The following is a description of a gene set: Genes predicted to be targets of miRBase v22 microRNA mmu_miR_6358, mmu_miR_6376 in miRDB v6.0 with MirTarget v4 prediction scores > 80 (high confidence targets). studied in species Mus musculus from publication Chen Y, Wang X (PMID 31504780) Mouse Gene Set: MIR_6358_MIR_6376, and this is the list of marker genes: Rsf1 (remodeling and spacing factor 1), Ocrl, Cdyl, Naa50, Tlcd1, Golph3, Vps13d, Erlin2, Gnaq, Fitm2, Trp53tg5, Clock, Meis2, Shroom4 (shroom family member 4), Srsf6, Tent4b, Elp4, Tbc1d1, Adamtsl4, Tktl1, Loxl3, Carmil1, Rreb1, Fut9, Brwd3, Ptprb, Chic2, Ube2r2, Meis1, Dab1, Scarb2, Itsn2, Ppfia1, Alg8, Ormdl2, Pold3, Ngfr